The following is a description of a gene set: Reactome Pathway: Interleukin-1 processing part of: Interleukin-1 family signaling studied in species Homo sapiens The IL-1 family of cytokines that interact with the Type 1 IL-1R include IL-1α (IL1A), IL-1β (IL1B) and the IL-1 receptor antagonist protein (IL1RAP). IL1RAP is synthesized with a signal peptide and secreted as a mature protein via the classical secretory pathway. IL1A and IL1B are synthesised as cytoplasmic precursors (pro-IL1A and pro-IL1B) in activated cells. They have no signal sequence, precluding secretion via the classical ER-Golgi route. Processing of pro-IL1B to the active form requires caspase-1, which is itself activated by a molecular scaffold termed the inflammasome. Processing and release of IL1B are thought to be closely linked, because mature IL1B is only seen inside inflammatory cells just prior to release. It has been reported that in monocytes a fraction of cellular IL1B is released by the regulated secretion of late endosomes and early lysosomes, and that this may represent a cellular compartment where caspase-1 processing of pro-IL1B takes place. Shedding of microvesicles from the plasma membrane has also been proposed as a mechanism of secretion. These proposals superceded previous models in which non-specific release due to cell lysis and passage through a plasma membrane pore were considered. However, there is evidence in the literature that supports all of these mechanisms and there is still controversy over how IL1B exits from cells (Brough & Rothwell 2007). A calpain-like potease has been reported to be important for the processing of pro-IL1A, but much less is known about how IL1A is released from cells and what specific roles it plays in biology., and this is the list of marker genes: GSDMD, NFKB2, IL1A, CTSG, IL1B, CASP1, IL18, RELA, NFKB1